The following is a description of a gene set: from publication Cao J, O'Day DR, Pliner HA, Kingsley PD, Deng M, Daza RM, Zager MA, Aldinger KA, Blecher-Gonen R, Zhang F, Spielmann M, Palis J, Doherty D, Steemers FJ, Glass IA, Trapnell C, Shendure J (PMID 33184181) species: Homo sapiens Marker genes curated from the annotated cluster as represented in the Descartes Human Gene Expression During Development database. The gene expression program underlying the specification of human cell types is of fundamental interest. The study authors generated human cell atlases of gene expression and chromatin accessibility in fetal tissues. For gene expression, the study authors applied three-level combinatorial indexing to >110 samples representing 15 organs, ultimately profiling ~4 million single cells. The study authors leveraged the literature and other atlases to identify and annotate hundreds of cell types and subtypes, both within and across tissues. Our analyses focused on organ-specific specializations of broadly distributed cell types (such as blood, endothelial, and epithelial), sites of fetal erythropoiesis (which notably included the adrenal gland), and integration with mouse developmental atlases (such as conserved specification of blood cells). These data represent a rich resource for the exploration of in vivo human gene expression in diverse tissues and cell types. Human Gene Set: DESCARTES_FETAL_STOMACH_GOBLET_CELLS, and this is the list of marker genes: UGT2B15, A4GNT, GKN1, MUC6, LGR5, IL17C, FGF20, CXCL5, CA9, FBP2, CXCL1, GKN2, SLC22A8, TFF2, MUC5AC, CSF3